The following is a description of a gene set: Genes positively differentially expressed in cell type: Neutrophil upon treatment with cytokine: IL-36α in mouse lymph nodes in vivo. species: Mus musculus Mouse Gene Set: CUI_NEUTROPHIL_IL36A_RESPONSE_UP from publication Cui A, Huang T, Li S, Ma A, Pérez JL, Sander C, Keskin DB, Wu CJ, Fraenkel E, Hacohen N (PMID 38057668) Cytokines mediate cell-cell communication in the immune system and represent important therapeutic targets. A myriad of studies have highlighted their central role in immune function, yet we lack a global view of the cellular responses of each immune cell type to each cytokine. To address this gap, the authors created the Immune Dictionary, a compendium of single-cell transcriptomic profiles of more than 17 immune cell types in response to each of 86 cytokines (>1,400 cytokine-cell type combinations) in mouse lymph nodes in vivo. A cytokine-centric view of the dictionary revealed that most cytokines induce highly cell-type-specific responses. For example, the inflammatory cytokine interleukin-1β induces distinct gene programmes in almost every cell type. A cell-type-centric view of the dictionary identified more than 66 cytokine-driven cellular polarization states across immune cell types, including previously uncharacterized states such as an interleukin-18-induced polyfunctional natural killer cell state., and this is the list of marker genes: Chmp4b, Rnasel, Pnp, Lrg1, Srgn, Rsad2, Nampt, Isg20 (interferon-stimulated protein), Fth1, Ifitm3, Xbp1, Casp4, Trim30a, Lilrb4b, Glipr2, Il1r2 (interleukin 1 receptor, type II), Smox, Ifi204, Cd300lf, Gbp7, Gbp2, Trafd1, Slfn4, Irgm1, Ifi47, Cxcr2